Given this list of marker genes Bmp4 (bone morphogenetic protein 4), Ctnnd1, Kirrel3, Notch2, Notch3, Mtss1, Mef2c, Pdgfrb, Tcf21, Pdgfra, Ahr, here is a description of the gene set: Mouse Gene Set: GOBP_GLOMERULUS_MORPHOGENESIS The process in which the anatomical structures of the glomerulus are generated and organized. The glomerulus is a capillary tuft surrounded by Bowman's capsule in nephrons of the vertebrate kidney. species: Mus musculus